The following is a description of a gene set: Genes predicted to be targets of miRBase v22 microRNA mmu_miR_6982_3p in miRDB v6.0 with MirTarget v4 prediction scores > 80 (high confidence targets). studied in species Mus musculus Mouse Gene Set: MIR_6982_3P from publication Chen Y, Wang X (PMID 31504780), and this is the list of marker genes: Cd84, Epb41l1, Coq8a, Mmp16, Dcx, Arhgef2, Blcap, Gsg1l, Bahd1, Lrp2, Rundc3a, Smim12, Slc19a1, Adcy1, Wasf2, Lgalsl, Eftud2, Degs1l, Tmem120b, Prdm16, Unc119, Mmp17, Ptpa, Ypel2, 1110065P20Rik, Grik4, Unc5a, Crocc2, Ggt7, Mmp15, Gnb3, Or5b95, Nckipsd (NCBI Gene Id 80987), Gng4, Nptx1, Tbx4, Ppp1r16b, Mtss2 (NCBI Gene Id 244654), Esrp1, Lrriq4, Smagp, Clec11a, Cacna2d2, Aplf, Baz2a, Cnr1, Rgs6